The following is a description of a gene set: studied in species Homo sapiens The chemical reactions and pathways resulting in the formation of hydrogen peroxide (H2O2), a potentially harmful byproduct of aerobic cellular respiration which can cause damage to DNA. Human Gene Set: GOBP_HYDROGEN_PEROXIDE_BIOSYNTHETIC_PROCESS, and this is the list of marker genes: ACOX1, DUOXA1, SOD1, DUOXA2, MPV17L, MAOB, DUOX2, CYBB, NCF1, CYP1A1, FYN, DUOX1, CYP1A2, ZNF205, CYBA, STAT3, SOD2